Given this list of marker genes Upb1, Upp2, Entpd5, Dctpp1, Nt5c, Dut, Upp1, Tymp (NCBI Gene Id 72962), Nt5m, Entpd4, Cda, Entpd7, Nt5c3, Dpyd, Dpys, Entpd4b, here is a description of the gene set: studied in species Mus musculus Mouse Gene Set: GOBP_PYRIMIDINE_NUCLEOTIDE_CATABOLIC_PROCESS The chemical reactions and pathways resulting in the breakdown of a pyrimidine nucleotide, a compound consisting of nucleoside (a pyrimidine base linked to a deoxyribose or ribose sugar) esterified with a phosphate group at either the 3' or 5'-hydroxyl group of the sugar.